The following is a description of a gene set: Absent foveal reflex Human Gene Set: HP_ABSENT_FOVEAL_REFLEX Lack of the foveal reflex, which normally occurs as a result of the reflection of light from the ophthalmoscope in the foveal pit upon examination. The foveal reflex is a bright pinpoint of light that is observed to move sideways or up and down in response to movement of the opthalmoscope. studied in species Homo sapiens, and this is the list of marker genes: RLBP1, PRPH2, PDE6G, RPGRIP1, PDE6H, RHO, CNGB3, RBP4, OFD1 (NCBI Gene Id 8481), RDH5, TLCD3B, RPGR, HPS6, ATF6, GNAT2, PDE6C, RS1, RPE65, CACNA1F, CNGA3